Given this list of marker genes PEX5, PEX6, TRIM37, PEX7, PEX10, USP9X, LONP2, PEX13, PEX14, PEX2, PEX26, PEX1, PEX12, PEX5L, PEX16, here is a description of the gene set: Human Gene Set: GOBP_PROTEIN_IMPORT_INTO_PEROXISOME_MATRIX studied in species Homo sapiens The import of proteins into the peroxisomal matrix. A peroxisome targeting signal (PTS) binds to a soluble receptor protein in the cytosol, and the resulting complex then binds to a receptor protein in the peroxisome membrane and is imported. The cargo protein is then released into the peroxisome matrix.